The following is a description of a gene set: The process in which neuroepithelial cells of the neural tube give rise to Brgmann glial cells, specialized bipotential progenitors cells of the cerebellum. Differentiation includes the processes involved in commitment of a cell to a specific fate. studied in species Homo sapiens Human Gene Set: GOBP_BERGMANN_GLIAL_CELL_DIFFERENTIATION, and this is the list of marker genes: ABL1, MAP2K1, MAPK1, GPR37L1, VIM, TTC21B, GFAP, SHH, PTPN11, MAPK3, PLPP3